Given this list of marker genes LZTFL1, IL7R, BRD4, IFT140, WDR26, DYNC1H1, NOTCH2, MIA3 (MIA SH3 domain ER export factor 3), DCLRE1C, GJA1, CANT1, DOCK6, MMP23B, USP7, IHH, SOX9, VPS13B, CERT1, GLI3, ADAMTSL2, HBA1, PORCN, ALOXE3, MSL3, ACVR1, TTC21B, CTSK, PPM1D, TWIST1, COL2A1, IFT172, CAMK2G, MGP, MAPK8IP3, SF3B4 (NCBI Gene Id 171), RECQL4, IGF1R, FIG4, TBCE, MEG3, FAT4, PIGS, SIM1, H4C3, TBC1D24, FGFR3, TELO2, ZMIZ1 (zinc finger MIZ-type containing 1), SALL1, KNSTRN, CTCF, SNORD116-1, SNORD115-1 (NCBI Gene Id 338433), IFT122, LBR, GPC3, PIGG, TBL1XR1, ABCC9, RTL1, SMARCA4, DACT1, DYNC2H1, NSDHL, HDAC6, COX4I1, SMC1A, KCNJ8, ADNP, ALMS1, RAG1, TBX22, NOG, WDR19, KDM5C, UBE4B, LRP4, ADA, HTT, SPECC1L, NOTCH1, DYM, KCNJ2, CHD7, MECP2, SRY, PIGL, B3GLCT, ASAH1, EP300, HERC2, RNU4ATAC, BMP2, PDPN, PIGF, RAB33B, KDM4B, COL3A1 (NCBI Gene Id 1281), ZNF407, ASCC3, RMRP, FBXL4, SLC26A2, HNRNPR, NDN, CHST11, CEP120, IFT52, HOXD13, SLC35C1, GNAS, TRPS1, SMC3, HBA2, CASZ1, FGD1, WASF1, SNRPN, CDKL5, LIG4, GPC4, PRKG2, KCNAB2, KCNN3 (NCBI Gene Id 95947), CRELD1, PIGV, NSD2, ROBO1, BPNT2, NGLY1, DYNC2I2, SPEN, PRKCZ, RAB3GAP2, NSUN2, EOGT, VPS35L, TCF4, SVBP, PIGN, ZFX, COL11A1, IL2RG, IQCE, ASXL1, CPLX1, GHR, APC, GABBR2, OCA2, PRMT7, FLI1, LAS1L, NPAP1, DYNC2LI1, BHLHA9, FBN1, WLS, RBPJ, UBAP2L (ubiquitin associated protein 2 like), C12orf57, SMOC1, SHOX, RAB23, KCNH1 (NCBI Gene Id 8656), PDGFRB, COG4, TRPV4 (transient receptor potential cation channel subfamily V member 4), AHDC1, BGN, DYNC2I1, NEK1, HINT1, UBE2A, TRIP11, FLNB, DLX5, TBX5, POC1A, TRRAP, LETM1, NTNG1, CTBP1, FGFRL1, HUWE1, CDC42BPB, MYCN, PHF6 (NCBI Gene Id 84438), LMNA, ERI1, FGFR2, RIPK4, SMAD4 (NCBI Gene Id 4089), PDE4D, CENPE, NELFA (negative elongation factor complex member A), SMARCA2, CCDC28B, INPPL1, GDF5, ARID1B, EBF3, FAM50A, NIPBL, ROR2, ERF (ETS2 repressor factor), COG1, BMPR1B, LMBR1, ITPR1, TUBB3 (NCBI Gene Id 94749), WNT7A, MASP1, RSPRY1, GRIP1, PTH1R, PHYH, FMR1, NPR2, CHSY1, FGFR1, ADAMTS2, PWRN1, OFD1, HEPHL1, EIF4A3, HDAC4, WNT10B, MAP3K7, VAC14, SATB1, CCBE1, HEATR3, DCHS1, IFT80, EZH2, SATB2, PTHLH, DHCR7, RAD21, PUF60 (NCBI Gene Id 22827), ZMYM2, ARL6, SKI, SPART, MBD5, WDR81, TONSL, DYRK1A, HSPG2 (heparan sulfate proteoglycan 2), GABRD, KMT2A, SIN3A, HDAC8, BBS1, LTBP3, KIAA0753 (KIAA0753), PRKAR1A, RAG2, SALL4, PWAR1, LUZP1, PEX7, KCNJ5, CHD6, KAT6A, DNMT3A (DNA methyltransferase 3 alpha), FLNA, PIK3CD, KIF5C (NCBI Gene Id 7860), CCDC47, ARSL, MKRN3, MAGEL2 (NCBI Gene Id 54551), FBXO11, TP63, TNNT3, RNF2, ALOX12B, GPX4, ARHGAP31, CUL4B, HOXA13, SIL1, SON, TBX3, ATP6V1B2, MAP3K20 (NCBI Gene Id 51784), TAF6, WDR35, USP9X, DLK1, TGDS, GALNT2, DLL4, TPR, PRDM16 (PR/SET domain 16), RERE, here is a description of the gene set: Aplasia/Hypoplasia involving bones of the feet studied in species Homo sapiens Human Gene Set: HP_APLASIA_HYPOPLASIA_INVOLVING_BONES_OF_THE_FEET